The following is a description of a gene set: Human Gene Set: GOBP_REGULATION_OF_SYSTEMIC_ARTERIAL_BLOOD_PRESSURE_BY_ENDOTHELIN species: Homo sapiens The process in which endothelin modulates the force with which blood passes through the circulatory system. Endothelin is a hormone that is released by the endothelium, and it is a vasoconstrictor., and this is the list of marker genes: RHOA, NOS3 (nitric oxide synthase 3), ECE1, EDN3, EDN2, EDN1